The following is a description of a gene set: XAV939 binds to the catalytic sites of tankyrase 1 and 2 and inhibits the ADP-ribosylation of AXIN1 and 2. Treatment of cells with XAV939 significantly increases the protein, but not the mRNA levels of AXIN1 and 2 and supports a strong increase in the level of GSK3beta-AXIN complexes. These cells also show increased phosphorylation of beta-catenin, decreased beta-catenin protein levels and a corresponding decrease in beta-catenin dependent transcription. Treatment of DLD-1 cells with XAV939 has also been shown to inhibit proliferation. XAV939 has not been tested in a clinical setting. Reactome Pathway: XAV939 stabilizes AXIN species: Homo sapiens part of: Signaling by WNT in cancer, and this is the list of marker genes: TNKS2, TNKS